Given this list of marker genes FGGY (FGGY carbohydrate kinase domain containing), PCNX3, WFS1, HARS2, XBP1, CYTH1, DHX57, WIPF1, BAZ1B, ARRB1, NSMAF (neutral sphingomyelinase activation associated factor), CAPRIN2, PIBF1, EBAG9, ATP13A2, STX17, FZD3, H2AZ1, RALBP1, C15orf40, BLTP3B, ARHGAP12, MMACHC, SAMD10, SNRPB, STAMBPL1, CASP8, SLAMF9, TRIM8, CMPK2, SUGP1, CBR4, E4F1, OXA1L (OXA1L mitochondrial inner membrane protein), BTBD1, KDM3A, PACS2, FZD7, ABL1, TOPBP1, CXCR4, MRPS14, FNBP1, RBM18, RECK (reversion inducing cysteine rich protein with kazal motifs), ASCC2, POC5, NUDT3, C16orf87, NUDT13, SELENOS, EXTL3, MED11, UBP1, OARD1, TIPIN, BIN3, MAF1, PCYT1A, TRIM59, GOT1, DTL, FOXD3, COMMD9, ADCY9, SDHD, KLHL21, BAG1 (NCBI Gene Id 573), NDUFAF4, ADAM23, MCM7, YIPF5, ATP13A1, CPTP, MRPS2, CORO1C, MYO5A, PREB, KLHL42, C22orf39, SMC2, SYS1, PRRG2, PHC1 (NCBI Gene Id 283368), TCTE1, SH3BP5L, PAPOLG, RRP36, BCL7B, TDP2, PRPS1, ETNK1, SMC6, SIRT7, TMC6, SPG11, MAU2, DOC2A, SP4, MLYCD, ANKRD13A, NFIL3, GDI1, VTI1B, SOX4, NAT1, SLC4A1AP, DFFB, ECPAS, G6PC2, PNPO, ATP5MC2, ATAD2B, PLD1, FNBP4, CDC37L1, CAPN2, PAXBP1, RTP4, KCNN4, DDHD2, KDM3B, NOL7, MYC, FAM118B, ETFRF1, PA2G4, MTX1, CCDC25, TMEM131L (NCBI Gene Id 23240), TUBGCP5, MED4, TRIM39, CLK2, USP33 (ubiquitin specific peptidase 33), CCNJ, MAPK14, ITPA, POLR3F, RPS6, ZFAND2A, CNR2, CERK, UQCRC2, RPP14, IRF7, SLC12A7, BORCS5, PURA, TIPARP, NDRG4, PHAX, PATZ1, MTARC2, BFAR, NR2C2AP, UBE2G2, M6PR, HLX, PJA2, MAFB, AMACR, ETFBKMT, SRP19, LUZP1, IVNS1ABP, MFAP1, MAPK9, SEPHS2, DBR1 (debranching RNA lariats 1), ANAPC4, SPINT1, DRAM1, CERT1, MINPP1, SLAIN2, SCAF4, GTPBP2, NUP133, SPO11, CRYBA4, CAPZA1, GLTP, EXOSC1, MIA3, KCNK13, SEC11C, FBXW7, RHO, GNB1L, ACOT8, KDM5A, MGAT1, BRWD1, C7orf25, TBPL1, UBAC1, ORMDL1, ZNFX1, METTL22, here is a description of the gene set: species: Homo sapiens mouse primary BMDCs were stimulated with tlr ligands and gene expression changes were profiled on Affymetrix arrays from publication Amit I, Garber M, Chevrier N, Leite AP, Donner Y, Eisenhaure T, Guttman M, Grenier JK, Li W, Zuk O, Schubert LA, Birditt B, Shay T, Goren A, Zhang X, Smith Z, Deering R, McDonald RC, Cabili M, Bernstein BE, Rinn JL, Meissner A, Root DE, Hacohen N, Regev A (PMID 19729616) Human Gene Set: GSE17721_POLYIC_VS_CPG_2H_BMDC_UP Genes up-regulated in comparison of dendritic cells (DC) stimulated with poly(I:C) (TLR3 agonist) at 2 h versus DC cells stimulated with CpG DNA (TLR9 agonist) at 2 h.